Given this list of marker genes DLG1, ATP1B1 (NCBI Gene Id 481), NPPA, ATP1A1, AKAP6, MIR30D, KCNA5, KCNH2, KCNE5, CACNA2D1, KCNJ5, AKAP9, KCNE1, MIR29B1, CAV3, KCNJ3, NEDD4L, KCNH6, AKAP7, SLC24A4, ANK2, FLNA, MIR328, RNF207, ZMPSTE24, KCNE3, NOS1, CACNA1D, YWHAE, ATP1A2, KCNE4, KCNE2, SCN2B, KCNQ1, SCN4B, KCND2, KCNA1, SCN5A, ADCY10, KCNIP1, ATP1B3, KCND3, KCNJ2, MIR1-1, CACNB3 (calcium voltage-gated channel auxiliary subunit beta 3), KCNJ8, MIR133A1, CAV1, NOS1AP, WDR1, ATP1B2, GJA5, KCNIP2, CASQ2, SCN1B, KCNN2, SNTA1, KCNK16, here is a description of the gene set: The process in which ions are transported across a membrane such that the membrane potential changes in the repolarizing direction, toward the steady state potential. For example, the repolarization during an action potential is from a positive membrane potential towards a negative resting potential. species: Homo sapiens Human Gene Set: GOBP_MEMBRANE_REPOLARIZATION